The following is a description of a gene set: studied in species Mus musculus Regulation of RUNX3 expression and activity Mouse Gene Set: REACTOME_REGULATION_OF_RUNX3_EXPRESSION_AND_ACTIVITY, and this is the list of marker genes: Psmd2, Psmd11, Psmb3, Psmb5, Psmc4, Cbfb, Psmd13, Ubb, Runx3, Psmc6, Psmd7, Smurf1, Tgfb1, Uba52, Psmd1, Psma7, Psmb7, Psma3, Psmd12, Psma2 (NCBI Gene Id 19166), Psmc3, Psma5, Psmd6, Psma1, Psmc5, Psmd14, Psma6, Ep300, Rps27a, Psmd3, Psmb6, Psma4, Psmb1, Psmb4, Smurf2, Mdm2, Psmd8, Adrm1, Psmc2, Psmc1, Ubc, Uba52rt, Src, Psmb2 (proteasome (prosome, macropain) subunit, beta type 2)